Given this list of marker genes KMT5C, WWTR1, ZNF346, CEP97, PI15, ADAMTS17, AFAP1L1, SPSB4, TLL1, EIF3J, KIAA1549 (KIAA1549), HAPLN3, ANKRD13B, SH3GLB1 (NCBI Gene Id 51100), BAK1, PPIC, CD276, ZNF704, TET3, PRPF40A, NSD1, DLG2, ISG20L2, DYNLT1, WDR41, ZNF282, BTG2, COL2A1, SGMS2 (sphingomyelin synthase 2), PCGF3, COL4A5, PURG, SERBP1, COL22A1, MCL1, GPR37, DRD1, RAPH1, LYPLA1, SLC6A14, PLEKHA8, SVIL, IGF1, ZC4H2, MAP4K4, FOXJ2, COL25A1, MBTD1, FREM2, DLGAP1, RGS1, MOG, KIF26A, EML6, PRKG1, RNF19A, ANKRD27, ZHX3, ELF2 (NCBI Gene Id 1998), HMCN1, PGAP2, ATP1B4, ZMYM2, RIC1, PMP22, DCUN1D4, DTWD2, AMMECR1L, COL5A2, CSGALNACT2, CLDN1, STMN2, DCAF12, PDIK1L, OTULIN, IFFO1, METAP2, AMMECR1, GRIP1, KNOP1, NID2, DGKH, RALA (RAS like proto-oncogene A), TMEM178B, DGKD, ZNF28, XKR7, RHOBTB1, MATCAP2, P3H2 (NCBI Gene Id 55214), ITGA6, SGCB, TMEM134, ZNF512B, ROBO1, ZFP36L1, C11orf54, COL4A1, USP31, SH3PXD2A, RFX7, FSTL1, SPARC, ZMIZ1, EFNA5, SIRT1, SGK1, KLHL28, SPRY4, ZDHHC21, COL15A1, GOLGA7, ZBTB5, LYSMD1, COL5A3, COL19A1, SESTD1, ANKRD13C, CBX6, LPL, PAN2, COL7A1, ATAD2B, RBAK, SETDB1, MAPRE1, FAM241A, FERMT2, TNFRSF1A, TFEB, SIKE1, GPATCH2, TET2, COL3A1, TDG, CSRNP2, IFI30, COL6A3, KIF26B, SPRN, ING3, NPAS3, COL1A1, AKT3, CAMK4 (calcium/calmodulin dependent protein kinase IV), BACH2, E2F7, MAP6, ADAMTS9, SIDT2, SERPINH1, KCTD3, ADAMTS6, SNTB2, DDX3X, COL1A2, NFIA, RLF, NAV3, IQCJ-SCHIP1 (NCBI Gene Id 100505385), FEM1B, ASAP2, SMIM21, BCORL1, JAZF1, ADAMTS10, CCNJ, PXYLP1, ELOVL4, IREB2, NUFIP2, HIF3A, EML5, SLC16A7, CFL2, ZBTB34, COL5A1, CALM3, PTP4A1, ZKSCAN4, DPYSL5, CCNT2, IL1RAP, ZNF469, RAB30 (RAB30, member RAS oncogene family), MARK3, CCSAP, TMEM236, ADAMTS7 (NCBI Gene Id 374629), EIF4E2, NCKAP5, DICER1, BMF, SLC16A14, NEXMIF, ERCC6, HBP1, FGA, INA, TMEM183A, NASP, ITGA11, KPNA1, TFAP2C, FBN1, AKAP5, YWHAH, PDS5B, EPC1, CLEC2D, KDM4B, SHROOM2, NKIRAS2, CBX1, SLK, RNF39, SMTNL2, NAV1, DNMT3B, here is a description of the gene set: from publication Chen Y, Wang X (PMID 31504780) Human Gene Set: MIR5682 species: Homo sapiens Genes predicted to be targets of miRBase v22 microRNA hsa-miR-5682 in miRDB v6.0 with MirTarget v4 prediction scores > 80 (high confidence targets).